Given this list of marker genes ACTR6, YY1, BRD8, SRCAP, INO80D, ACTR5, INO80C, YY1AP1, UCHL5 (ubiquitin C-terminal hydrolase L5), ACTL6A, RUVBL2, CFDP1, ANP32E, DMAP1, TRRAP, RUVBL1, INO80B, INO80E (INO80 complex subunit E), INO80, ZNHIT1, ING3, KAT5 (lysine acetyltransferase 5), MCRS1, EP400, ACTR8, TFPT, NFRKB, here is a description of the gene set: studied in species Homo sapiens Human Gene Set: GOCC_INO80_TYPE_COMPLEX A chromatin remodeling protein complex initially purified from S. cerevisiae and containing more than 10 subunits, including the SWR1-related complexes. INO80 (inositol requiring 80)-type complexes have diverse functions, including promoting transcriptional activation and DNA repair.